Given this list of marker genes CTNS, DMP1, SLC34A1, GATM, FGF23, CYP27B1, NDUFAF6, CLCN5, NHERF1, SLC34A3, INPPL1, EHHADH, PHEX, ENPP1, GNAS, here is a description of the gene set: Renal phosphate wasting species: Homo sapiens High urine phosphate in the presence of hypophosphatemia. Human Gene Set: HP_RENAL_PHOSPHATE_WASTING